Given this list of marker genes RAC1, SLIT2, SRGAP1, ARHGAP39, CDC42, SRGAP2 (SLIT-ROBO Rho GTPase activating protein 2), SRGAP3, ROBO1, here is a description of the gene set: studied in species Homo sapiens Human Gene Set: REACTOME_INACTIVATION_OF_CDC42_AND_RAC1 Inactivation of CDC42 and RAC1